Given this list of marker genes NTRK3, SRC, PIK3CA (phosphatidylinositol-4,5-bisphosphate 3-kinase catalytic subunit alpha), IRS1 (NCBI Gene Id 3667), NTF3, PIK3R1, here is a description of the gene set: The PI3K complex, composed of PIK3R1 and PIK3CA, co-immunoprecipitates with NTRK3 (TRKC), activated by NTF3 (NT-3) treatment. Activation of NTRK3 correlates with activating phosphorylation of AKT, the main mediator of PI3K signaling, and is dependent on PI3K activity. NTRK3-mediated activation of PI3K signaling depends on SRC activation and the adaptor protein IRS1, but the exact mechanism is not known. Reactome Pathway: Activated NTRK3 signals through PI3K studied in species Homo sapiens part of: Signaling by NTRK3 (TRKC)